The following is a description of a gene set: The process whose specific outcome is the progression of the glomerular mesangium over time, from its formation to the mature structure. The glomerular mesangium is the thin membrane connective tissue composed of mesangial cells, which helps to support the capillary loops in a renal glomerulus. studied in species Homo sapiens Human Gene Set: GOBP_GLOMERULAR_MESANGIUM_DEVELOPMENT, and this is the list of marker genes: ACTA2, EGR1, IL6R, GPR4, PDGFRB, FOXC2, MIR125A, CD34, CFLAR, BMP7, NOTCH1, ITGB3, WT1, PDGFA, SERPINB7, PDGFB, PDGFD, BMP4